The following is a description of a gene set: from publication Schaefer CF, Anthony K, Krupa S, Buchoff J, Day M, Hannay T, Buetow KH (PMID 18832364) studied in species Homo sapiens Human Gene Set: PID_IL2_PI3K_PATHWAY IL2 signaling events mediated by PI3K, and this is the list of marker genes: GAB2, HSP90AA1, RPS6KB1, JAK1, EIF3A, BCL2L1, RPS6, AKT1, MYC, MYB, MTOR, IL2RB, RELA, LCK, PIK3R1, BCL2, PRKCZ (protein kinase C zeta), RAC1 (NCBI Gene Id 5879), FOXO3, SGMS1, TERT, IL2, NFKB1, UGCG, IL2RA, IL2RG, GRB2, SOS1, PTPN11, SHC1, JAK3, E2F1, PIK3CA, SMPD1